The following is a description of a gene set: from publication Amit I, Citri A, Shay T, Lu Y, Katz M, Zhang F, Tarcic G, Siwak D, Lahad J, Jacob-Hirsch J, Amariglio N, Vaisman N, Segal E, Rechavi G, Alon U, Mills GB, Domany E, Yarden Y (PMID 17322878) species: Homo sapiens Human Gene Set: AMIT_EGF_RESPONSE_20_MCF10A Signaling pathways invoke interplays between forward signaling and feedback to drive robust cellular response. In this study, we address the dynamics of growth factor signaling through profiling of protein phosphorylation and gene expression, demonstrating the presence of a kinetically defined cluster of delayed early genes that function to attenuate the early events of growth factor signaling. Using epidermal growth factor receptor signaling as the major model system and concentrating on regulation of transcription and mRNA stability, we demonstrate that a number of genes within the delayed early gene cluster function as feedback regulators of immediate early genes. Consistent with their role in negative regulation of cell signaling, genes within this cluster are downregulated in diverse tumor types, in correlation with clinical outcome. More generally, our study proposes a mechanistic description of the cellular response to growth factors by defining architectural motifs that underlie the function of signaling networks. Genes whose expression peaked at 20 min after stimulation of MCF10A cells with EGF., and this is the list of marker genes: RAD23B, SLC39A7, PSMD13, MMP14, AQP3, SCD, SRPRA, SCARB2, SEMA3F, MDFI, PHTF1, THBS1